The following is a description of a gene set: Reactome Pathway: Mitochondrial translation termination This event has been computationally inferred from an event that has been demonstrated in another species.<p>The inference is based on the homology mapping from PANTHER. Briefly, reactions for which all involved PhysicalEntities (in input, output and catalyst) have a mapped orthologue/paralogue (for complexes at least 75% of components must have a mapping) are inferred to the other species. part of: Mitochondrial translation species: Mus musculus electronically inferred by orthology from the curated human pathway, and this is the list of marker genes: Mrpl23, mt-Nd3, Mrpl17 (mitochondrial ribosomal protein L17), Mrpl52, Mrps35, Oxa1l, Mrpl51, Mrrf, Mrps33, Mrps26, Mrpl34, mt-Nd4l, Mrpl36, Mrpl2, Mrpl57, Mrpl1, Mrps18c, Mrpl28, Mrpl11, Mrpl13, Mrpl54, Mrpl35, Mrpl16, Mrpl32, Mrpl27, Mrps12, Mrpl3, Mrpl21, Mrps21, mt-Atp8, Mrpl22, Mrps6, Mrpl58, Mrpl14, Aurkaip1, Mrps36, Mrpl47, Mrpl53, mt-Nd6, Mrpl40, Mrpl4, Mrps7, Mrps17 (NCBI Gene Id 66258), mt-Cytb, Mtrf1, Mrpl55, Mrpl33, Mrps16, Mrpl15